Given this list of marker genes AURKB, CLVS1, RPS15A, FRG1, PRR5 (NCBI Gene Id 86335), STAG1, NRP1, FADS1, SYNGR2, FH, ADRA2A, ELOA, TEX261, CDC45, RALA, EXOSC10, WDR82, BCL2L11, GALC, LDAH, CD83, CSF1R, PSMB9 (NCBI Gene Id 92051), GPD2, MYBL2, MNS1, HNF1B, SEC14L1, EIF2AK4, PRKCD, F2RL2, LCP1, CKS1B, VPS25, PRIM1, CKS2 (NCBI Gene Id 1164), TCP1, SELENOW, MRPL36, THOC3, XPO7, MRPL52, RPL15, RRM1, TUBB, CACUL1, NUDT9, KCMF1, NHERF2, RPS8, DCTN5, NAA35, CDC25C, HMBOX1, FEN1, CDK2, MBTPS1, DAGLB, SHC1, CERK, UGGT1, KIF1A, RUFY1, LGALS3, PIK3CD, DEF8, FAU, NAGA, KGD4, SMYD1, UNC93B1, CNOT3, POLE2, ADCYAP1R1, UCHL5, SF3A1 (splicing factor 3a subunit 1), CD9, KCNAB2, CIAO2A, REXO2, PPIH, CWC15, BCL7C, CENPV, RPSA, RAI1, HTR1A, VIPAS39, PRIM2, PPP1R21, CXCR4, LSM2, TRAF1, MACROH2A1, CHRAC1 (chromatin accessibility complex subunit 1), RING1, TCF19, IMP4, CLCC1, LCK, HINT1, FKBP1B, RPUSD4, CYTIP, CD53, FCRLA, UBAC2, DNAJC5, KDR, AHCY, AURKA, GRN, NCBP1, RAD51AP1, ATP7A, STK10, RPA1, PADI2, KIFC1, PPP1R14B, UGT8, POLR1H, LATS2, OLFM1, MRPL33 (mitochondrial ribosomal protein L33), TCF3, DCLRE1A, TMEM268, IFNGR1, ADPRH, NTPCR, RASL11B, FCHO1, MX2, SELL, MBP, EXTL3, HIGD2A, ADK, SFPQ, CDK9, ST3GAL5, TRIM27, RAD54L, ABCF2, LIMD1, CCL22, PPT2, SMAP2, POLD2, SPATA13, PDGFB, RPS19, MECP2, DNMT1, HLA-DMA, KIF22, PRKCB, RYR1, RPS11, EXT1, ANGPTL4, TSN, CCR2 (C-C motif chemokine receptor 2), WAS, KDM1A, C19orf12, ASAH1, GNG3, CLDN8, PLP2 (NCBI Gene Id 5355), COPS5, RACGAP1, CEP250 (NCBI Gene Id 11190), GNG10, SNX12, TWF2 (NCBI Gene Id 11344), NNT, ITGB5, ANXA3, ARHGDIA, NOP10, NCAPH, PPARD, SPI1, GNS, GUSB, RFC1, CAPZB, THRAP3, PPP1R12C, TACC3, SCARB1, RPS3, GLI1, NDRG1, VPS26B (VPS26 retromer complex component B), TINF2, PDE6G, FANCM, here is a description of the gene set: species: Homo sapiens The expansion, trafficking and functional effectiveness of adoptively transferred CD8+ T-cells play a critical role in mediating effective anti-tumor immunity. However, the mechanisms which program the highly proliferative and functional state of CD8+ T-cells are not completely understood. We hypothesized that IL-12, a cytokine commonly induced by TLR activation, could enhance T-cell priming by altering responsiveness to antigen and cytokines. Priming of tumor specific CD8+ T-cells in the presence of IL-12 induced the acquisition of a 'polyfunctional' effector response and increased the generation of memory cells. Moreover, IL-12 priming also promoted high levels of the IL-2 receptor alpha-chain (CD25) and robust IL-2 mediated activation of STAT5. This sensitivity to IL-2 translated into enhanced in vivo proliferation of adoptively transferred CD8+ T-cells. Furthermore, real-time, in vivo imaging of T-cell trafficking confirmed the ability of IL-12 priming to drive in vivo proliferation. IL-12 priming enhanced the anti-tumor function of adoptively transferred cells by reducing established subcutaneous tumor burden, and significantly increasing survival in an established intracranial tumor model. Finally, IL-12 priming of human PBMCs generates tumor specific T-cells phenotypically and functionally similar to IL-12 primed Pmel-1 T-cells. These results highlight IL-12 as an important mediator of CD8+ T-cell effector function and anti-tumor immunity. from publication Lisiero DN, Soto H, Liau LM, Prins RM (PMID 21430221) Human Gene Set: GSE22443_IL2_VS_IL12_TREATED_ACT_CD8_TCELL_DN Genes down-regulated in Pmel-1 CD8 T cells primed with cognate antigen: IL2 versus IL-12.